Given this list of marker genes H2AZ2, CSNK2A1, SLC7A1, MYBL2, PNN, CD1C (NCBI Gene Id 911), TCERG1, RAD21, AURKB, PRPS1, SH2D1A, LMNB1, KNTC1, CCNA2, ZNF43, LARP7, RAD54L, EZH2, POLA1, RHOH, UNG, HMGB2, USP49, AURKA, MRE11, PRKDC, BUB3, MTF2, STAT5A, NCAPD2 (non-SMC condensin I complex subunit D2), SRSF10 (serine and arginine rich splicing factor 10), CDC7, SSBP2, RRM1, TCF3, DDX39A, NFYB, NFATC2IP, ANP32E, NEMP1, NDC80, PCLAF, CENPA, EXOSC8, XPO1, TOP1, CNOT9, BLM, HMGN1, CHEK2, ASF1A, CEP57, CCNF, ZNHIT3, ZWINT, RBBP8 (RB binding protein 8, endonuclease), SUZ12, DUT, CD47, DNAJC9, RBBP4, ABCB7, NAE1, COPS3, TOP2A, MCM4, FANCI, CDK1, ILF3, CBX3, TFDP2, RFC4, SMC4, MPHOSPH9 (M-phase phosphoprotein 9), TAF11, GINS1, UBE2S, KATNA1, SMC1A (NCBI Gene Id 8243), DNMT1, PPP1CC, RB1, NCK1, HMMR, RPA1, KIF20B, TMEM131L, IDH3B, SKP2, UBE2C, CHAF1A, GTSE1, PMS2P3 (NCBI Gene Id 5387), MCM5 (minichromosome maintenance complex component 5), CDKN2C, PAXIP1, RFC3, ZNF330 (NCBI Gene Id 94900), RAD51AP1, TMPO, CAD, ESPL1, ACYP1, FRG1, SMC3, FOXM1 (forkhead box M1), ATP11B, PAICS, RAD51C, SNRPA, TTF2, DEK, POLR2B, PPP2R5C, TIMELESS, ATM, DDX39B, PSIP1, SRSF3, NASP, MCM2, EIF3H, DDX46, CNTRL, KIFC1, NSD2, RIF1, CDC20, SRSF11 (serine and arginine rich splicing factor 11), SPC25, CTCF, ZNF131, LBR, SEC31A, DHFR, AATF, TOPBP1, SNRPB, CPSF4, CASP2, BLMH (NCBI Gene Id 642), HMGN4, MCM6, MKI67, SMC2, STMN1, SNRPA1, RPIA, TFDP1, BRCA2, POLE, FUBP1, MSH2, RECQL, CENPC, PRPF4, USP1, DCP2, METAP1, PCNA, CNOT3, MAT2A, MAD2L1, TBCA, DNA2, PLK4, BRCA1, RNASEH2B, here is a description of the gene set: from publication Pujana MA, Han JD, Starita LM, Stevens KN, Tewari M, Ahn JS, Rennert G, Moreno V, Kirchhoff T, Gold B, Assmann V, Elshamy WM, Rual JF, Levine D, Rozek LS, Gelman RS, Gunsalus KC, Greenberg RA, Sobhian B, Bertin N, Venkatesan K, Ayivi-Guedehoussou N, Solé X, Hernández P, Lázaro C, Nathanson KL, Weber BL, Cusick ME, Hill DE, Offit K, Livingston DM, Gruber SB, Parvin JD, Vidal M (PMID 17922014) Genes constituting the XPRSS-Int network: intersection of genes whose expression correlates with BRCA1, BRCA2, ATM, and CHEK2 in a compendium of normal tissues. Human Gene Set: PUJANA_XPRSS_INT_NETWORK Many cancer-associated genes remain to be identified to clarify the underlying molecular mechanisms of cancer susceptibility and progression. Better understanding is also required of how mutations in cancer genes affect their products in the context of complex cellular networks. Here we have used a network modeling strategy to identify genes potentially associated with higher risk of breast cancer. Starting with four known genes encoding tumor suppressors of breast cancer, we combined gene expression profiling with functional genomic and proteomic (or 'omic') data from various species to generate a network containing genes linked by 866 potential functional associations. This network shows higher connectivity than expected by chance, suggesting that its components function in biologically related pathways. One of the components of the network is HMMR, encoding a centrosome subunit, for which we demonstrate previously unknown functional associations with the breast cancer-associated gene BRCA1. Two case-control studies of incident breast cancer indicate that the HMMR locus is associated with higher risk of breast cancer in humans. Our network modeling strategy should be useful for the discovery of additional cancer-associated genes. species: Homo sapiens